Given this list of marker genes Rab31, Adgre1, Lyz2, Hp, Glrx (NCBI Gene Id 97899), Serpinb1a, Cybb, Spint2, Ltf, Pgd, Cd177, Aldh2, Dgat2, Itgam, Camp, Hdc, Irf8, Casd1, Cebpa, Prtn3, Anxa1, Mmp8, Lgals1, Il18, S100a8, Csf2ra, Fpr2 (NCBI Gene Id 319437), S100a9, Lbp (NCBI Gene Id 16803), Lcn2, here is a description of the gene set: Mouse Gene Set: KAMIKUBO_MYELOID_CEBPA_NETWORK Dominant RUNX1 inhibition has been proposed as a common pathway for CBF leukemia. CBF beta-SMMHC, a fusion protein in human acute myeloid leukemia (AML), dominantly inhibits RUNX1 largely through its RUNX1 high-affinity binding domain (HABD). However, the type I CBF beta-SMMHC fusion in AML patients lacks HABD. Here, we report that the type I CBF beta-SMMHC protein binds RUNX1 inefficiently. Knockin mice expressing CBF beta-SMMHC with a HABD deletion developed leukemia quickly, even though hematopoietic defects associated with Runx1-inhibition were partially rescued. A larger pool of leukemia-initiating cells, increased MN1 expression, and retention of RUNX1 phosphorylation are potential mechanisms for accelerated leukemia development in these mice. Our data suggest that RUNX1 dominant inhibition may not be a critical step for leukemogenesis by CBF beta-SMMHC. Network of differentially expressed myeloid genes centered around CEBPA. studied in species Mus musculus from publication Kamikubo Y, Zhao L, Wunderlich M, Corpora T, Hyde RK, Paul TA, Kundu M, Garrett L, Compton S, Huang G, Wolff L, Ito Y, Bushweller J, Mulloy JC, Liu PP (PMID 20478528)